The following is a description of a gene set: studied in species Homo sapiens Any process that modulates the establishment or extent of a membrane potential in the depolarizing direction away from the resting potential in a ventricular cardiomyocyte. Human Gene Set: GOBP_REGULATION_OF_VENTRICULAR_CARDIAC_MUSCLE_CELL_MEMBRANE_DEPOLARIZATION, and this is the list of marker genes: MIR1-1, SCN3B, GJA5, SMAD7, GPD1L, SCN5A, CAV3